The following is a description of a gene set: studied in species Mus musculus Mouse Gene Set: WP_GPCRS_PEPTIDE GPCRs, peptide, and this is the list of marker genes: Avpr1a, Lhcgr, Oprl1, Grpr, Oprk1, Npy2r (NCBI Gene Id 18167), Ccr9, Ednra, Cxcr5, Ccr8, Ccr6, Ccr1l1, Cxcr2, Mc3r, Agtr1a (NCBI Gene Id 72294), Bdkrb1, Sstr3, Galr3, Ccr7 (C-C motif chemokine receptor 7), Cxcr6, Mc1r, Sstr2, Cckbr, Tacr2, Oprd1, Cx3cr1, Oprm1, Galr1, Tacr3, Ntsr2, Galr2 (galanin receptor 2), Tacr1, Cxcr3, Mc5r (melanocortin 5 receptor), Fpr1, Cxcr4, Ghsr, Ccr5, Ccr2, Nmbr, Sstr5, Sstr4 (NCBI Gene Id 20608), Avpr2, C3ar1, Npy6r, Brs3, Agtr1b, Ccr10, Ntsr1, Mc4r, Mc2r, Bdkrb2, Trhr, Avpr1b, Sstr1, Ccr3, Cckar, Agtr2, Oxtr, Ccr1, Gnrhr, Fshr, Ednrb, Npy4r, Npy1r (NCBI Gene Id 18166), Ccr4, C5ar1, Npy5r, Fpr3, Tshr